The following is a description of a gene set: The process by which normal somatic cells reach an irreversible stage of cell cycle arrest following multiple rounds of replication; this end stage is associated with marked changes in gene expression and function. This is a natural barrier to unlimited proliferation of somatic cells, and is believed to be contolled by telomere shortening. species: Mus musculus Mouse Gene Set: GOBP_REPLICATIVE_SENESCENCE, and this is the list of marker genes: Mme, Cdkn2a, Pla2r1, Trp53, Atr, Atm, Ercc1 (NCBI Gene Id 13870), Wnt16, Serpine1, Tert, Romo1, Ctc1, Wrn